The following is a description of a gene set: The aggregation, arrangement and bonding together of a set of components to form the spindle during a meiotic cell cycle in females. An example of this is found in Drosophila melanogaster. species: Mus musculus Mouse Gene Set: GOBP_SPINDLE_ASSEMBLY_INVOLVED_IN_FEMALE_MEIOSIS, and this is the list of marker genes: Fbxo5, Ska3, Ska1, Cenpe, Pten, Ska2, Ccnb2, Septin1, Ddb1, Dcaf13, Aurka, Ndc80